The following is a description of a gene set: Genes down-regulated in CD133+ cells (hematopoietic stem cells, HSC) compared to the CD133- cells. Human Gene Set: JAATINEN_HEMATOPOIETIC_STEM_CELL_DN Human cord blood (CB)-derived CD133+ cells carry characteristics of primitive hematopoietic cells and proffer an alternative for CD34+ cells in hematopoietic stem cell (HSC) transplantation. To characterize the CD133+ cell population on a genetic level, a global expression analysis of CD133+ cells was performed using oligonucleotide microarrays. CD133+ cells were purified from four fresh CB units by immunomagnetic selection. All four CD133+ samples showed significant similarity in their gene expression pattern, whereas they differed clearly from the CD133- control samples. In all, 690 transcripts were differentially expressed between CD133+ and CD133- cells. Of these, 393 were increased and 297 were decreased in CD133+ cells. The highest overexpression was noted in genes associated with metabolism, cellular physiological processes, cell communication, and development. A set of 257 transcripts expressed solely in the CD133+ cell population was identified. Colony-forming unit (CFU) assay was used to detect the clonal progeny of precursors present in the studied cell populations. The results demonstrate that CD133+ cells express primitive markers and possess clonogenic progenitor capacity. This study provides a gene expression profile for human CD133+ cells. It presents a set of genes that may be used to unravel the properties of the CD133+ cell population, assumed to be highly enriched in HSCs. from publication Jaatinen T, Hemmoranta H, Hautaniemi S, Niemi J, Nicorici D, Laine J, Yli-Harja O, Partanen J (PMID 16210406) species: Homo sapiens, and this is the list of marker genes: ACSL6, IL18RAP, CD8A, GPR18, GABARAPL1, PTGDR, ITGAM, CDKN2D, SPON2, OLIG1, IGF2R, JAZF1, SLC14A1, SELENBP1, C5AR1, CD5, ZFP36L1, LAT, CD36, HBB, RHD, LBH, PF4V1, S100A9, DENND2D, NKG7, CHRM3-AS2 (NCBI Gene Id 100508768), FGL2, HBG1, CD8B (CD8 subunit beta), RASGRP1, ABCC13, PLBD1, MEGF9, LY9, NELL2, LRRN3, FCER1G, FCGR2A, CD3D, RGCC, LTF, CD247, GZMH, FPR1, CCL4, TFDP1, SNCA, CYBB, DEFA1, GPR65, GIMAP4, ANKRD55, RGS1, ZER1, ARL4C, EEIG1, FYB1, CCL5, QPCT, PRF1, UPP1, TRDC, SAMHD1, CEBPD, S1PR5, CITED2, CD86, TNFAIP3, TGFBI, MNDA, TYROBP, CTSB, GZMK, PF4, HCK, FCN1 (ficolin 1), CD2, PNP, ITK, RHAG, IFI30, VSIG1, GNLY, IGSF6, F5, COTL1, IL2RB, CD163, ITGB2, XK, HBZ, CMTM5, OLFM4, LDLRAP1, SLC2A3, CYP1B1, MYL4, TUBB2A, CHI3L1, CD27, IL1RN, LGALS3, KRT1, KCTD12 (potassium channel tetramerization domain containing 12), CST7, SECTM1, PVRIG, STX11, KLRB1, BLVRB, SERPINB2, RGS18, CLEC7A, TGFBR3, GYPA, TRAT1, CCR7, NEXN, PASK, MAL, MAN1C1, MIR22HG, CX3CR1, SLFN5, FGR, TRABD2A, F13A1, EPHA4, FGFBP2, LEF1, FCGR3B, MMP8, KLRC1, S100A12, SERPINA1, SH2D1B, SLC4A1, GZMA, CXCL16, LYZ, GPCPD1, TOB1, MYBL1 (NCBI Gene Id 649850), CPVL, ADTRP, RBP7, LCK, MS4A6A, TESC, IL7R, CLEC10A, RCAN3, MPEG1, PLXDC1, DCAF12, ISG20, PCSK5, CSTA, CTSH, SULF2, KLRF1, CALD1, STK17A, ALAS2 (NCBI Gene Id 90735), THBS1, DOCK9, RASGRF2, CCL3, ARG1, BPGM, NCF2, TENT5C, IL10RA, NPL, ZAP70, SGSH, TMC5, S100A8, MMP9, BCL2L11, IL21R, GZMB, BCL11B, KLF1, SGK1, THEMIS, CRISPLD2, KLF2, CD1D, TUBB1, AQP3, TRBC1, DOK2, ANKRD9, HBA1, PYHIN1, CD28, CEACAM8, CA1, PSAP, TXNIP, CDK5R1, CAMK4 (NCBI Gene Id 814), CTSE, ETS1, CYP4F3, RTN1, CD14, LGALS2, PPBP, IL13RA1, RORA, PRKCA, CTTN, CLEC4A, HBM, NID1, KLRK1, XCL1, CCR1, AHSP, TENM1, SLC25A37 (NCBI Gene Id 55881), FBLN7, MARCHF2, ITGB2-AS1, SNTB2, KLF4, SAMD3, PIK3R5, CYSTM1, HBD, VCAN, LILRA5